The following is a description of a gene set: from publication Chen Y, Wang X (PMID 31504780) Genes predicted to be targets of miRBase v22 microRNA hsa-miR-4663 in miRDB v6.0 with MirTarget v4 prediction scores > 80 (high confidence targets). Human Gene Set: MIR4663 species: Homo sapiens, and this is the list of marker genes: PCYT1B, PDIK1L, RAC2, ATPAF1, NKX3-1, TRIM33, SNX4, DNAI7, SEMA4C, USP24, BSDC1, USP3, LGSN, AFF3 (NCBI Gene Id 3899), PDYN, TMEM174, ZNF655, KCNIP4, PAK3, FGF14, EXO1, FTO, IRF6, WNK3, FXYD6, GOLIM4 (golgi integral membrane protein 4), RPS3A, FYCO1, ABCG2, BOLL, SLC29A3, VSTM2L, FAM98A (NCBI Gene Id 25940), PKD1L1-AS1, ATAD2B, CHRM1, ASAP3, PRKAB1, SESN3, STK19, UBR1, VEZF1, SYNJ1, FUT9, VASH2, TOP2A (DNA topoisomerase II alpha), COL19A1, GPR17, MEIS2, NUDCD2, CDCP1, SMAD7, EIF3J, MIER1, CREB3L1, CCDC6, WFDC1, TBC1D28, NFASC, AKTIP, MAP6, SV2C, SCN1B, DBX2, PKIA, CUX1